Given this list of marker genes ANKRD46, MAP3K10, FASTKD1, CMPK1, RNASE6, TIMP2, PLEKHF1, WDR11, RSRP1, KCTD15, RFC5, CCDC34, AIMP1, GAREM1, PDXP, SLC35B3, RMND5B, PADI4, PACC1, TMEM129, RCAN3, MR1, CGREF1, ARHGAP9, MIGA1, AP5B1, IFTAP, CNPY3, WDHD1, C6orf136, TTC5, LAIR1, MRPS26 (mitochondrial ribosomal protein S26), NICN1 (nicolin 1, tubulin polyglutamylase complex subunit), NUMA1, NCOA1, KCNAB2, MICAL1, ABCB10 (NCBI Gene Id 23456), B3GNT3, GPR27, EEF1AKMT1, TTC33, D2HGDH, DHCR7, SLC24A4, BTBD1, UBE2T, FOXO3, F8A1, MPPE1, GBA2, BICDL1, TPRKB, LRRC56, SCCPDH, LGMN, ERCC5 (NCBI Gene Id 2073), MRPS34, GPS2, CRYGS, DNAJC5B, POC1B, GRK5, SLC36A2, BRI3BP, ANLN, POLR2G, NCKIPSD (NCK interacting protein with SH3 domain), BBS10, GLCE, ALDH18A1, DMAC2L (distal membrane arm assembly component 2 like), C10orf120, ATPAF1, PPIH, ENOPH1, HTR2B, XKR5, FLI1, CLEC1A, CEP83-DT, RAD18, CYP27A1, TRIM27, DPH1, RHOBTB1, CDC42SE1, ARPC5L, NFIC (nuclear factor I C), TMEM60, PABIR2, BORA, CD27-AS1, COA8, TSNAX, SERPINA7, GPR183, GCSH (glycine cleavage system protein H), MGST1, ST13 (NCBI Gene Id 8937), C11orf54, MYO15A, RP9, ERCC6L, CHAD, KAT7, SARS1, HELB, ABCB7, ZSCAN12, ADI1, CEP44, ALB, LYL1, TUSC2, TRIP6, IFT140, MIA2, RPAP1, TRIM28, SLC25A42 (solute carrier family 25 member 42), TRUB1, ASNSD1, RBL2 (RB transcriptional corepressor like 2), P2RY10, CDC25B, RASSF7, NGRN, VCPKMT, DLG3, POLR3F, POLR2B, SLC35C2, SCMH1, MFNG, ORMDL2 (NCBI Gene Id 94102), MRPL51, DNAAF2, PPA2, QRSL1, HADH (NCBI Gene Id 3033), FZD4, SSNA1 (NCBI Gene Id 8636), PFKFB1, GNG10, TECPR2, RNASE4, DDI2, HEPACAM2, AATK, ELF2, ABCD3, SLC2A8, ACTL7A, SLC37A4 (NCBI Gene Id 84965), DHX32, HS2ST1, ARB2A, PPM1J, CBX5, AFG1L, AK3, DUSP22, PDIK1L, RMND1, TIPIN, IL6ST, DHRS3, CDK9, HEBP1 (heme binding protein 1), PIGX, SMIM11, TPK1, OPN3, GHRH, ZNF692, PLPP5, DPAGT1, GPR108 (G protein-coupled receptor 108), ATRAID, BDH1, PMP2, LIAS, CREB3L2, CORO1C (NCBI Gene Id 23603), ZNF436, TNFAIP8L1, TMEM40, ORMDL1, RHBDD3, STRADB, ZNF274 (NCBI Gene Id 51732), INPP5E, NUDT7, IFT46, TBC1D24, TOX3, PHLDA3, ZBTB45, here is a description of the gene set: Genes down-regulated in comparison of dendritic cells (DC) treated with CpG DNA (TLR9 agonist) DNA versus the untreated cells. from publication Stetson DB, Medzhitov R (PMID 16413926) studied in species Homo sapiens Bone marrow-derived dendritic cells were left untreated or stimulated with lipid-transfected double-stranded DNA or CpG oligonucleotides for four hours before harvesting. Human Gene Set: GSE2197_CPG_DNA_VS_UNTREATED_IN_DC_DN